The following is a description of a gene set: Human Gene Set: HP_HYPOPLASIA_OF_THE_PRIMARY_TEETH studied in species Homo sapiens Hypoplasia of the primary teeth Developmental hypoplasia of the primary teeth., and this is the list of marker genes: ERCC8, GJA1, ERCC6, ERCC4, UBR1, PCGF2, ERCC1